The following is a description of a gene set: studied in species Homo sapiens The gene expression program underlying the specification of human cell types is of fundamental interest. The study authors generated human cell atlases of gene expression and chromatin accessibility in fetal tissues. For gene expression, the study authors applied three-level combinatorial indexing to >110 samples representing 15 organs, ultimately profiling ~4 million single cells. The study authors leveraged the literature and other atlases to identify and annotate hundreds of cell types and subtypes, both within and across tissues. Our analyses focused on organ-specific specializations of broadly distributed cell types (such as blood, endothelial, and epithelial), sites of fetal erythropoiesis (which notably included the adrenal gland), and integration with mouse developmental atlases (such as conserved specification of blood cells). These data represent a rich resource for the exploration of in vivo human gene expression in diverse tissues and cell types. Human Gene Set: DESCARTES_FETAL_CEREBRUM_SKOR2_NPSR1_POSITIVE_CELLS Marker genes curated from the annotated cluster as represented in the Descartes Human Gene Expression During Development database. from publication Cao J, O'Day DR, Pliner HA, Kingsley PD, Deng M, Daza RM, Zager MA, Aldinger KA, Blecher-Gonen R, Zhang F, Spielmann M, Palis J, Doherty D, Steemers FJ, Glass IA, Trapnell C, Shendure J (PMID 33184181), and this is the list of marker genes: PDE11A-AS1, PCP4, SUDS3P1, LIN28AP2, ADGRL2, YBX2P1, IL1RAPL2, SPINT1, HSPA12A, LINC02458, DNAJC5G, SLC18A3, PROP1, HAR1A, SKOR1, KCTD8, ABCA17P, FOXP4-AS1, ARHGEF33, ITPR1, SYT2, PDE11A, ATP2B2-IT2, LINC01630, DAB1-AS1, ESRRB, ZNF385D (NCBI Gene Id 79750), MED28P8, RSU1P3, NPSR1, LINGO3, API5P2, LINC00353, RORA, TFAP2A-AS1, FGF3, RNU6-1131P (NCBI Gene Id 106480064), ARG1, FGF19, KCTD9P2, TDRD5, CALB1, ATP2B2-IT1, GNAT3, NDNF, PPP1R2P5, BSPH1 (binder of sperm protein homolog 1), AIPL1, ST13P20, COL6A5, FAM153A, ENSG00000234953, WNT16, RORA-AS2, LINC01047, RNA5SP51, SKOR1-AS1, GPC3, TRPC3, ZNF385D-AS2, TFAP2A, CORIN, PDE1C, NGFR, LINC01440, ENSG00000254394, POLR2DP2, WDR95P, PTGER3, POSTN, FOXP4 (forkhead box P4), CA8, FAM153CP, HS3ST2, LINC00559, TRIM54, RNU6-1175P, EBF3, SKOR2, CFTR, LINC01108, COL6A6, SPINT1-AS1, CHRNA3, ENSG00000229588, TAF4B, TRIM60P13, LINC02336, PRMT8